Given this list of marker genes NMI, PALM, OSBPL8, SAMD9, LILRB1, CD37, NAPA, BTK, ZCCHC2, NCOA1, SIRPA, TLE4, TCF7L2, FGL2, RAPGEF2, DENND3, LCN2, DYSF, UIMC1, CLEC4E, KLF6, SIPA1L1, S100A11 (NCBI Gene Id 6282), STK17B, CDK19, MAP1LC3B, LRRFIP1, CD63, SECTM1, DNAI1, IFNGR1, DENND5A, PTEN (phosphatase and tensin homolog), RAPGEFL1, NFYA, CYBB, HK3, ZNF200, DHRS12, TRIOBP, HAUS4, GBP1, GNB2, PADI4, CCPG1, RRAGD, RNF19B, H2BC12, APMAP, PACSIN2, DBN1, SLCO3A1, ADIPOR1, CFD, PSD4, ICAM1, NRBF2, GIT2, PTPRE, CREB5, APAF1, ANXA3, B9D2, ZNF267, WDR26, ATP6V1B2, RHOG, BLOC1S1, RNF141, APLP2, XKR8, TST, RGS4, BAZ2B, GTPBP1, CHSY1, SH3GLB1, COTL1, MAP2K4, MMP9, SLK, RARA, PLXNC1, ALDOA, APOL1, LY96, RTF2 (NCBI Gene Id 51507), IRF2, HMX1, IMPDH1, IMPA2, KLF7, SOS2, PFKFB3, CERS2, RPS6KA1, ZNF516, CUL3, FTL, KIF5B, SEC14L1, TMBIM4, BMP2K, PGD, HSPBAP1, SLC6A6, LMNB1, POLB (NCBI Gene Id 5423), TRAPPC14, IL1RAP, VPS8, MAFG, HLA-C, SLC2A3, TNFAIP2, SRF, RAB7A, TOR1B, HPSE, KDM6A, F2RL1, SPINT1, ADAM8, ZNF106, FOSL2, NIBAN1, CEACAM3, NOP10, IFIH1, HBB, ARPC3, BCL6, ADGRE2, CYB5R1, RRAGC, PELO, RHBDF2, AGTPBP1, CYTH4, CYP4F2 (cytochrome P450 family 4 subfamily F member 2), GMPR2, DAZAP2, HIGD1B, IRF9, PSTPIP2, CHMP1A, GMIP, HEXIM1, SLPI, ITGB2, KLHL2, ANPEP, H3C2, MYO5A, CFLAR (CASP8 and FADD like apoptosis regulator), LIMK2, ADGRV1, IFIT1, E2F3, CCNH, EIF4EBP2, CYTIP, FOSL1, TNFRSF1A, UCP1, SH2B2, S100A12, GPR65, PLA2G4C, HAS2, ADGRE5, SQOR, STK38L, CALML4, NQO2, CSAD (NCBI Gene Id 51380), SULT1B1, CDC42EP2, EIF4G3, TMCC1, KBTBD2, SLC15A3, CDKN2D, ZYX, MPPE1, TRIM8, MICALL2, TNFSF13, PPM1A, YBX3, LAT2, DOCK5 (NCBI Gene Id 80005), PRCP, PPP2R5A, EVI2A, NRDC, HLA-A, B3GALT4, TNNI2, CEBPA, here is a description of the gene set: Human Gene Set: GSE3982_NEUTROPHIL_VS_CENT_MEMORY_CD4_TCELL_UP species: Homo sapiens In the present study we used Affymetrix oligonucleotide microarrays to produce gene transcription profiles for the major leukocyte types in humans. This comprehensive dataset enabled us to not only establish which genes were expressed in each leukocyte type, but also which genes were expressed in each subset after activation. The used of a comprehensive dataset of gene profiles from all the major human leukocyte subsets enabled a novel and powerful means for identification of genes associated with single leukocyte subsets, or different immune paradigms. from publication Jeffrey KL, Brummer T, Rolph MS, Liu SM, Callejas NA, Grumont RJ, Gillieron C, Mackay F, Grey S, Camps M, Rommel C, Gerondakis SD, Mackay CR (PMID 16474395) Genes up-regulated in comparison of neutrophils versus central memory CD4 T cells.